The following is a description of a gene set: Human Gene Set: GOBP_MEMBRANOUS_SEPTUM_MORPHOGENESIS The process in which the membranous septum is generated and organized. The membranous septum is the upper part of ventricular septum. species: Homo sapiens, and this is the list of marker genes: ID2, TGFB2 (NCBI Gene Id 7042), FGFR2, NSD2, FZD2, FZD1, NOG, VANGL2, BMP4, TGFBR2